Given this list of marker genes PIK3CA, STAT3, ELK4, MAPK3, MAPK1, PDPK1, CREB1, GNAI3, FOS, GNAI2, MAP2K3, BRAF, RHOA, MAPKAPK2, MAP2K1, HTR1E, RAP1A, MAP3K1, ELK1, HTR1B, HTR1F, ITPR1 (inositol 1,4,5-trisphosphate receptor type 1), GNAQ, GNAO1, GNAI1, RPS6KA5, RASGRP1, MAPKAPK3, MAPK14, MAP2K2, JAK2, SRF, HTR1A, MAP2K6 (NCBI Gene Id 5608), HTR2A, HTR1D, RASGRF1, here is a description of the gene set: Human Gene Set: WP_SEROTONIN_HTR1_GROUP_AND_FOS_PATHWAY Serotonin HTR1 group and FOS pathway species: Homo sapiens